Given this list of marker genes CCDC85C, CSNK1D, NETO2, TMEM132D, MAP2, AQP9, AMMECR1, LHX6, PJA2, TMEM71 (transmembrane protein 71), NCOA2, POMC, WAPL, CDKL4, PXK, HIP1, STAM, WNT11, CTSC, VPS4B, GRIA3, GNAI1, ENSG00000273590, SLC30A7, SPDYE1, DENND1B, ADGRF4, SLC4A4, ATF6, FBN1, TMEM30A, DSE, MAPK9, AIDA, ERMN, LCORL, POU4F1, BORCS7, CEP170, SPARC, AK4, SPDYE5, SNX27, DAZL, AEBP2, FRMD5, RPS3A, AKAP11, WDTC1, CDK6, RHBDD1 (NCBI Gene Id 84236), TBC1D12, CDKL2, CDC7, TENM1, AGO1, SESN3, RABGGTB, TSHZ1, MTF1, HDAC9, DNAJC8, RPL15, RHOT1, CPA3, RAB11FIP1 (RAB11 family interacting protein 1), FGFR1OP2, NFIB, PRR14L, NUFIP2, UST, SESTD1, CELF3, SEPTIN7, SPDYE6, BCL7A, CEMIP2, SEC63, PRCP, POGLUT1, USP24, RPF1, HAUS2, ME1, TADA1, RYBP, SFTPA1, SPDYE3, PHIP, KCNJ15, CERT1, TBC1D10B, FRYL, PSEN1, KIDINS220, VPS29, SMIM11 (NCBI Gene Id 54065), ADM5, TTC9C, WIF1, TMEM87A, SRSF10, ACER3, COL4A1, POLR1D, GABRG3, ARFIP2, HAPLN1, NRIP3, CCDC146, DAZ1 (deleted in azoospermia 1), IGF1, MED26, SMAD5, VAMP7, DAZ3, ADAM9, OLFML1, SUPT3H, KIAA1549, CLCN3, DGKE, MARCHF8, RAB14, SLC35F1, IRF2BP2, NCAPG2, ZNF704, CCNG1, SMIM8, POGLUT3, MYO5C, CLEC1A, CYP7B1, BTBD7, here is a description of the gene set: studied in species Homo sapiens Genes predicted to be targets of miRBase v22 microRNA hsa-miR-6730-5p in miRDB v6.0 with MirTarget v4 prediction scores > 80 (high confidence targets). from publication Chen Y, Wang X (PMID 31504780) Human Gene Set: MIR6730_5P